Given this list of marker genes SLC3A1 (NCBI Gene Id 6519), GUCY2D, NADK2, SLC7A9 (solute carrier family 7 member 9), SLC7A7, SLC1A1, AASS, here is a description of the gene set: An elevated level of an aspartate family amino acid in the urine. species: Homo sapiens Increased aspartate family amino acid level in urine Human Gene Set: HP_INCREASED_ASPARTATE_FAMILY_AMINO_ACID_LEVEL_IN_URINE